Given this list of marker genes Ube2d1, Psmc1, Cited2, Rps27a, Psmd12, Psmb6, Psmb7, Hif1a, Vhl, Ajuba, Psma2, Psmd13, Ubb, Psma3, Psmb4, Psmc6, Epas1, Psmb5, Psmc4, Psma6, Psma5, Ep300, Psmd6, Psma7, Psmc2, Psma4, Psma1, Psmd7, Hif3a, Psmd1, Psmc3, Psmc5, here is a description of the gene set: This event has been computationally inferred from an event that has been demonstrated in another species.<p>The inference is based on the homology mapping from PANTHER. Briefly, reactions for which all involved PhysicalEntities (in input, output and catalyst) have a mapped orthologue/paralogue (for complexes at least 75% of components must have a mapping) are inferred to the other species. electronically inferred by orthology from the curated human pathway Reactome Pathway: Cellular response to hypoxia studied in species Mus musculus part of: Cellular responses to stress